Given this list of marker genes KRT1, C1R, TUFT1, UROD, EXPH5, PLOD1, LAMA3, MMP1, COL5A2, LAMB3, LAMC2, PDGFRB, B3GALT6, COL1A1, PPOX, CPOX, KRT5, FERMT1, PRKACA, COL5A1, ADAMTS2, PKP1, COL3A1, ITGB4, CAST, ITGA3, COL17A1, CHST14, JUP, COL7A1, PLEC, COL1A2, GATA1, DSP, KRT14, C1S, UROS, here is a description of the gene set: Fragile skin Skin that splits easily with minimal injury. Human Gene Set: HP_FRAGILE_SKIN studied in species Homo sapiens